The following is a description of a gene set: Mouse Gene Set: GOCC_CAMP_DEPENDENT_PROTEIN_KINASE_COMPLEX studied in species Mus musculus An enzyme complex, composed of regulatory and catalytic subunits, that catalyzes protein phosphorylation. Inactive forms of the enzyme have two regulatory chains and two catalytic chains; activation by cAMP produces two active catalytic monomers and a regulatory dimer., and this is the list of marker genes: Prkar1a, Prkar1b (NCBI Gene Id 19085), Prkar2a, Prkaca, Prkx, Prkab2, Prkacb, Prkar2b (protein kinase, cAMP dependent regulatory, type II beta), Akap14